The following is a description of a gene set: from publication Travaglini KJ, Nabhan AN, Penland L, Sinha R, Gillich A, Sit RV, Chang S, Conley SD, Mori Y, Seita J, Berry GJ, Shrager JB, Metzger RJ, Kuo CS, Neff N, Weissman IL, Quake SR, Krasnow MA (PMID 33208946) species: Homo sapiens Human Gene Set: TRAVAGLINI_LUNG_CLASSICAL_MONOCYTE_CELL, and this is the list of marker genes: ASAH1, RBP7, MYO1F, NRGN (neurogranin), RBM47 (RNA binding motif protein 47), ATP6V1B2, APAF1, LRRC25, INSR, IL6R, NCOA4, NUDT16, IFI30 (NCBI Gene Id 126359), RPLP1, S100A12, ZFAND5, PER1, DPYD (dihydropyrimidine dehydrogenase), CD300LF, SAT1, RPS24, FAR1, SULF2, NOTCH2 (notch receptor 2), ETS2, GASK1B, MNDA, NADK, FOS, COTL1, STK17B, YBX3, DMXL2, CD4, BLVRB, MAP3K1, ACSL1, KCNE3, NRG1, SCIMP, QKI (NCBI Gene Id 9444), P2RY13, MEF2C, PLEC, AOAH, NFE2, FPR1, DICER1, FCER1G, SKAP2, RAB31, CIMAP1B, FGD2 (NCBI Gene Id 221472), SLC11A1, FGD4, ZNF467, BRI3, DOK3, ACAP2, CYRIA, NLRP3, MFSD1, LTA4H, ENTPD1, CCR2, GLT1D1, CCNY, TRIM25, CCR1, SCPEP1, AHR, IL13RA1, TLR4, JDP2, RPS13, PTPRE, AHNAK, SAP30, NEAT1, ATP6V0B, S100A8, PABPC1, PYCARD, NICOL1, PGD, JMJD1C, POU2F2, USP3, MBD2, THBS1, S100A9, TMEM170B, NPC2 (NPC intracellular cholesterol transporter 2), TNFSF13B (TNF superfamily member 13b), TPT1, ADGRE2, IRAK3, AP1S2, CYP1B1, CD36, USP15, LGALS1, DUSP6, FAM120A, ARRB2, MIS18BP1, MGST1, SNX27, IRS2, C5AR1, PECAM1, S100A6, PELI1, EVI2B, LYZ, MARCHF1, ROGDI, CFP, GPX1, CYBB, TPP1, CPVL, LRP1, PILRA (NCBI Gene Id 29992), CRTAP (NCBI Gene Id 253263), EMILIN2, SLC24A4, SPTLC2, CLEC7A, STXBP2, CD33, MCL1, MEF2A, ZNF385A, FCN1, IL17RA, SULT1A1, CRISPLD2, TNFAIP2, CAPNS1, NCF2, ACTR2, FCGRT, TNFRSF1B, GNS, PRAM1, MEGF9, TET2, MAFB, FBXL5, HK2, C9orf72, AGO4, S100A4, MPEG1, UBE2R2, IFNGR1, CD86, MACROH2A1, APLP2, PLXDC2, UBXN11, VCAN, TYROBP, NCF1, KLF4, TLR2, CUX1, CARS2 (NCBI Gene Id 79587), CEBPB, SYK, TLR8, SRGAP2B, FCGR2A, NACC2, RNASE2, TSPO, CASP1, LGALS9, SLC12A6, GNAQ, CR1, CPPED1 (calcineurin like phosphoesterase domain containing 1), CSF3R, TKT (transketolase), CST3, CD1D (NCBI Gene Id 912), IQGAP1, CD93, DENND10, EHBP1L1, ITGAM, RNASE6, TRIP12, CREB5 (cAMP responsive element binding protein 5), TNFSF10, CEBPD, RNF144B (NCBI Gene Id 255488), ZEB2, FES, CLEC12A, CARD16, ZNF106, ASGR1, LY86, CD163, C19orf38, FGR, AGTPBP1, GAS7, TFEC, TMSB10, RTN3, KIAA0930, RAC1, BACH1, SERF2, HIPK3, NBPF14, CAST, CD300E, CTSS (cathepsin S), AGTRAP, HCK, FGL2, LPGAT1, RASSF3, PSAP, SMARCD3, HRH2, SERPINA1, CD14 (NCBI Gene Id 929), KYNU, TIMP2, KCTD12, RNF149, TNFRSF1A, PHC2, PLBD1, C1orf162, GPBAR1 (G protein-coupled bile acid receptor 1), APOBEC3A, LYN, PICALM, CSTA, SLC8A1, MS4A6A, EFHD2, CHST15, SPI1, LGALS2, TET3, PLEKHO1, RASSF2, NUMB, VMP1, NUP214, MTMR11, PRKAG2, TYMP, PYGL, SLC7A7, NFAM1, PPM1F, RNF130, TMT1A, LRRK2, LMO2, TGFBI, RXRA